The following is a description of a gene set: studied in species Homo sapiens Human Gene Set: GOBP_REGULATION_OF_RAC_PROTEIN_SIGNAL_TRANSDUCTION Any process that modulates the frequency, rate or extent of Rac protein signal transduction., and this is the list of marker genes: SSX2IP, GABARAP, SH3BP1, CADM4, PIK3CG, KBTBD6, ARHGAP24, STMN3, CCL19, OGT, RTN4, PIK3CB, TEK, FNTA, RASGRF1, KBTBD7, NF1, DOK7, MIR29B1, CRKL, AUTS2, CRK, ARHGAP17, KRAS, CDKL5, LRP4, ARF6, ALS2, MIR21, TNS3, ARHGAP44, CCR7